Given this list of marker genes DNM1L, ATM, MAPT, COL13A1, CCDC141, HSD17B4, CLCN1, BBS10, SLC9A1, DNASE1L3, NDUFV2, CLN5, NAA20, GRIN1, ATP6V1A, FASTKD2, PHYH, GCK, CTSD, DLL1, ACBD5, OPA1, SLC16A2, TAT, GCH1, NDUFA4, HNRNPH2, SEMA6B, ATXN7, HEXB, NPC1, SLC2A3, MAP2K1, MT-TI, RORA, CLPB, MARS1, MLC1, ZBTB11, NDUFB10, USF3, TRIM8, CFAP418, YWHAG, ERCC6, KIF7, PDE6D, WARS2, YWHAE, SLC5A6, PEX11B, LIN28B, FGFR1, SLC1A3, ARL13B, ATP5F1E, CELF2, NPHP3, GABBR2, STN1, NR5A1, SLC6A19, LYRM7, PUM1, SMARCA2, MT-CYB, HTT, REPS1, GABRB3, BBS5, SLC44A1, CISD2, RARS1, SYNGAP1, PNP, TNFSF4, TERC (NCBI Gene Id 7012), SACS, TBC1D23, IQCB1, MKRN3, KARS1, CLCN4 (chloride voltage-gated channel 4), NPHP1, PDE2A, FZR1, HUWE1, PIGT, PAFAH1B1, POLG (DNA polymerase gamma, catalytic subunit), SMC1A, COQ2, CARS1, SLC30A9 (NCBI Gene Id 10463), IFNGR1, MEG3, COQ5, PGM3 (NCBI Gene Id 5238), BBS9, PDHX, GALT, TLR4, TSPOAP1, MT-ND4L, ADPRS, SUPT16H, CEP104, FGF14, FLRT3, PYCR2, MT-ND2, CAPN1, CHAMP1, AP3B2, NCF1, PIGQ, HK1, TUBB4A, TRIO, POLR3A, LMNB2, KCNJ11, CREBBP, SPRY4, ERAP1 (NCBI Gene Id 51752), FKBP6, IMPDH2, NONO, NANS, COA7, DCHS1, SORL1, ACOX1, ATN1, SDHA, EXOSC5, NDST1, AAAS, DDB2, RFXAP, ATP13A2 (ATPase cation transporting 13A2), SLC4A10, HERC1, STAT3 (NCBI Gene Id 6774), ALG11, RTEL1, PANK2, NPHP4, TXN2, HMGCL, MED13L, VPS37D, SOX10, ZNF592, UCHL1, SPTAN1, AHI1, SMAD4, MT-ND1, NECAP1, ETHE1, VPS13D, FGF12, NDUFAF2, NDUFAF3, CCDC88C, MPZ, DNAJC3, TOP3A, CEP164, HIVEP2, NRCAM, FRMD5, HCRT, ATXN1, TIA1, CPS1, SETD2, POLR3B, SLC13A5, DLK1, CAMTA1, DEGS1, NDUFA1, NHLRC1, HEPACAM, THG1L, FGF8, LGI3, MT-TW, NEMF, KLRC4, MAGEL2, RUBCN, RFT1, MAST1, ABCD1, EED, HNRNPH1, IL23R, NDUFAF6, PRPS1, EIF2S3, NEXMIF, LONP1, PDGFB, TMEM106B, EPRS1, SLC6A8, AMFR, NELFA, SLC5A7, GLB1, SLC13A3, MCOLN1, TCN2, NPC2, SPTBN1, SPTBN2, STAT4, PLA2G6, CYFIP2, MT-ND5, CPLANE1, MYCN, TANC2, GPRC5B, ATXN10, NADK2, ATP9A, AIFM1, PNPLA6, CTDP1, BMPR1B, HNRNPA1, MSH4 (mutS homolog 4), SMARCE1, VPS41, TPM3, NAXD, MTFMT (NCBI Gene Id 123263), MVK, ELOVL5, WDR81, VLDLR, MAG, PRKN, NUS1, DCC, PLEKHG4, BBS2, PI4KA, BRCA1, GPI, MTHFR, GRM1, HPDL, SLC22A5, TRNT1, SLC32A1, IQSEC1, SIK1, GCDH, NTN1, CLN6 (NCBI Gene Id 54982), MT-ATP6, SRPK3, UBTF, RUSC2, PACS2, NGLY1, GTPBP2 (NCBI Gene Id 54676), FBXL4, COQ8A, GTF2H5, CAMK2B, NSD2, VARS2, TBK1, NTRK2, SUFU, TRANK1, ADA2, NUP62, PLD3, WDPCP, NAA80, UBE3C, YME1L1, HTRA1, FRRS1L, NRAS, ZEB2, DNAJC5, IFT140, METTL27, GABRA1, SEMA3A, TPR, ATP5F1D, PIDD1, CSF1R, SLC18A2, HIBCH, CACNA2D1, DARS1, LRP4, TTC8, DNAJC19, CDC42BPB (NCBI Gene Id 9578), PEX7, SLC7A6OS, AP1S2, TBL2, SNAP25, NFIX, TMEM163, CLN8, MICOS13, LIG3, PPT1, PIBF1, MYO5A, GNAO1, ALDH18A1, CTNNA2, MECR (mitochondrial trans-2-enoyl-CoA reductase), TANGO2, ARL3, ERCC3, DPM1, TUBG1, NAGS, OCA2, NPAP1, LRP12, PEX1, B9D1, GABRA2, DAB1, SET, KLHL41, NEDD4L, DGUOK, TMEM63A, NDUFB3, SGPL1, APC2, SLC19A3, XRCC1, NDUFA6, PROK2, ENSG00000288330 (NCBI Gene Id 724066), NOP56, PDGFRB, HLA-DRB1, USH1G, SPTLC1, RFC2, PPP1R21, STXBP1, SLC38A3, PSMC3IP, TIMMDC1, KNSTRN, GRM7, ARCN1, SLC25A22, GPAA1, MORC2, BBS4, GABRG2, TREM2, BAZ1B, PPP2R1A, LMO1, PRKCG, SLC6A5, PEX10, UROC1, PDCD6IP, L1CAM, ABCA7, MRPL12, KLLN, PEX13, ATAD1, SETX, IRF2BPL, PWAR1, SLC12A3, MPDU1, KATNIP, MKKS, PCDH15, TDP2, MT-TQ, NAXE (NAD(P)HX epimerase), CLTC, PIGY, SNX14, VPS13C, POLR3K, DNMT1, EP300, ELOVL4, RTN2, SLC25A15, MTTP, CSTB, APC, UQCRQ, CLCNKB, SIGMAR1, ACTL6B, ATP7B, MAN2B1, PITRM1, LETM1, COG8 (component of oligomeric golgi complex 8), AARS2, AGTPBP1, PRODH, TECPR2, ARSG, NDNF, LMNB1, DARS2, NEUROD2, MT-CO2, PIGG, PSEN2, SYT14, UBAC2, SYNE1, GABRB2, MAPK8IP3, SNRPN, XPC, VPS51, FTL, TTBK2, AHDC1, PAX6, SLC19A2, MPV17, MAN1B1, DCX (doublecortin), GTF2E2, FMR1, GABRD, HLCS, LAMA1, SYT2, TDP1, WDR26, SCN1A, RAD50, PRRT2, CAPN3, HLA-DQA1, MYPN (myopalladin), POGZ (pogo transposable element derived with ZNF domain), SCLT1, BBS7, ZNF365, SPTB, AFF2, SIL1, MKS1, BTD, GMPPB, CEP41, TUBB2B, FTH1, AP2M1, CYP7B1, STX1A, PAK1, CEP78, ARX, CTSH, ANK1, L2HGDH, DCPS, VAMP1, PNKP, TBC1D2B, WASHC5, ZFHX3 (NCBI Gene Id 463), PMPCB, RAI1, PEX26, CTCF, NDUFS7, KIF5A, ACBD6, SPR, MBD5, PDYN, ARV1, ADGRG1, EXOSC9, MARS2, SNORD118, RPGRIP1L, CACNA2D2, DNM1, PRF1, FLVCR1, MT-TV, CC2D2A, CYP27A1 (cytochrome P450 family 27 subfamily A member 1), SMC5, CSNK2A1, AP4M1, WDR11, LMBRD1, SPART, TAF1, NEU1, GABRB1 (gamma-aminobutyric acid type A receptor subunit beta1), CAV3, NFASC (NCBI Gene Id 23114), NAA60, BEAN1, GOSR2, NTNG1, MT-TL1, NDUFB11, ABCC8, DPAGT1, NSD1, GPHN, IVD, LIMK1, NARS1, TMEM270 (NCBI Gene Id 135886), LAGE3, LRPPRC, WARS1, RFC1 (NCBI Gene Id 5981), PWRN1, NDUFA11, TTI1, VRK1, SEC23B, ACADS (acyl-CoA dehydrogenase short chain), FEZF1, GABRA5, TRAPPC11, SCO2, SCN2A, KCND3, OPHN1, ATP2B3, WWOX, PSEN1 (presenilin 1), BRAF, MECP2, AP5Z1, SFXN4, PSAP, RTN4IP1, MTR (5-methyltetrahydrofolate-homocysteine methyltransferase), SLC17A5, ADGRV1, SMPD1, WFS1, FAT2, SLC26A4, APTX, CHMP1A, MTRFR, NIPA1, SLC35A1, CNKSR2, PROKR2, SNORD115-1, USH2A, BRAT1, SAMD9L, ALS2, APOE, ACADM, POLR1C, ATPAF2, NEFL, BSCL2, CIITA, NF2, CMPK2, C19orf12, SBF2, SLC1A2, RNF113A, MT-RNR1, FGF13, SLC46A1, TMEM138, GAMT, COQ4, PIEZO2, ROGDI, PIGL, BCS1L, MT-TP, NR4A2, VPS13A (vacuolar protein sorting 13 homolog A), CDK19, SMARCB1, NF1 (neurofibromin 1), NDUFAF8, TMEM237, GRIK2, TUBB, PDP1, ADAR, PIK3CA (NCBI Gene Id 5290), PIGK, GFAP, SLC39A4 (solute carrier family 39 member 4), UBAP1, AMACR, CHD8, APOB, CLCNKA, HIC1, MOG, RIPK4, TMEM126B, PDHA1, CTC1, ABCB7, PIGA, FSHR, SLC52A2, LYST, MMADHC, TMEM216, IFT74, FA2H, CDH23, SDHB, TTN, POU3F4, PAK3, FKRP, PPP1R15B, TSHB, NUP54, PRDX3, ATXN3, SNF8, LITAF, TRPC3, MYD88, HARS1 (histidyl-tRNA synthetase 1), CACNA1G, SPAST, LZTFL1, B9D2, ITPR1, RTL1, MPLKIP, FAS, MT-ND3, EPM2A, NDUFS2, TSFM, HAX1, WDR73, ARMC9, CRAT, NDUFAF1, NDUFAF4, RFX5, OTC, RDH11, CNTNAP2, NDUFS1, MT-TH, MT-ATP8, TRAF7, PGAP3, PPP2R5D, HCN1, RNF170, SYNJ1, CTSF, SCN8A, SLC4A1, PRDM8, PGK1, CAPRIN1, MTPAP, RAB11B, CHD2, ATG5, ATP8A2, SLC35C1, ATP5MK, HMBS, SLC52A3, MME, MT-TN, SMO (smoothened, frizzled class receptor), TPK1 (NCBI Gene Id 27010), IRF4, PARS2, SLC9A6, ALDH5A1, NDUFAF5, GBA2, SCN1B, KCNC3, SLC25A1, MEFV, TBP, ELOVL1, CAV1, INS, TARDBP, GLRA1, DKC1, VPS4A, WHRN, TPP1, ERCC1, OTUD6B, TOPORS, NSUN2, AFG3L2, SPG7 (NCBI Gene Id 87549), ATP5F1A, GLS, ERBB3, SRPX2, GSN, FUS, TOMM40, DHX30, RNU12, CXCR4, NPTX1 (neuronal pentraxin 1), HLA-B, USH1C, HERC2, UBE3A, TWNK (NCBI Gene Id 60508), CHD7, FBXW7, TBCE, PEX6, NEB, BMP15, SRD5A3, NDUFS4, GTF2I, ESPN, ABHD12, STUB1, LINGO1, NALCN, HSD17B10, VWA3B, MT-ND4, EPB42, GJB1, PEX16, GNB5, ARID1B, ARL6, KDM4B, NIPA2, SPTA1 (spectrin alpha, erythrocytic 1), SARDH, SCN9A, KBTBD13, MCM3AP, FOXG1 (forkhead box G1), SDCCAG8 (NCBI Gene Id 10806), PIK3R5, STX1B, CHP1, ACOX2, GCLC, SOD1, MYORG, PDHB, TCF4, ALK, FERRY3, NKX6-2, TMEM107 (NCBI Gene Id 84314), SPG11, ALG13, SCN3A, ANO10, FOXRED1, DNAJC30, ELN, TMEM67, MLXIPL, AKT1, SDHAF1, POMT2, SZT2, SPG21, ALG6, CRELD1, RNASET2, DEAF1, IL17RD, PIGV, CHCHD10, TINF2, SCAPER, STARD7, GRIN2A, FOXP2, UFC1, KCNA1, KCNB1, RNF216, ATCAY, SNORD116-1, BCL11A, RNASEH1, PMM2, TRAPPC6B, GDAP1, CLCN2, PNPT1, PIGS (NCBI Gene Id 94005), BCKDHA, KIF1B, ALG8, AQP4, P2RY11, H4C5, BSND, PRX, CPLX1, SLC25A4, RNF125, BOLA3, GRIN2D, PURA, SQSTM1, TNPO2, EXOSC8, HACE1, CWF19L1, TTPA (NCBI Gene Id 7274), DMXL2, GDAP2, GJC2, RNU4-2, GALC, APP, TPM2, IL10, PLP1, SDHD (NCBI Gene Id 91899), SATB1, MAB21L1, ARSA, MSTO1, KCNC2, KCNJ16, KIAA0753, ITM2B, DNAJC6, NDUFS6, DALRD3, SLC6A1, KIF1A, SIM1, CEP120 (NCBI Gene Id 153241), PTPN22, MFSD8, IFT172, COX6B1, ATP6V0A1, PEX3, PHOX2B, TMEM70, MFN2, FRMD4A, ACD, HESX1, ANOS1, PEX2, PDX1, ATP1A3, CEP290, SH3TC2, PIGP, RPL10, ASL, PRICKLE1, PTEN, CLIP2, ASS1, MYO7A, DMPK, PIK3CD, MT-CO1, PIGO, MT-TS2, CEP19, GJA1, PCDH19, TUBA1A, CHAT, VCP, ACTA1, TUBB3, C4A, TGFB1, CLTRN, KIAA0586, PEX5, MT-CO3, TRIM32, PEX12, NUP214, DUSP6, KDM5B, ATXN8OS, SHMT2, ALMS1, PGM2L1, PEX14, MICU1, SUMF1, TARS1, BAP1, CBY1, CTBP1, TMEM218, RIMS2, MT-TK, JAM2, GTF2IRD2, POLR1A, DHFR, PIGW, TH, ATP6V0A2, ATAD3A, COG5, COG4, ERCC8, XRCC4, NDUFS8, ZNF142, SLC25A46, AASS, SURF1, GTF2IRD1, FAM149B1, HLA-DQB1, GLRX5, OGDH (oxoglutarate dehydrogenase), TTC19, RPIA, ERCC4, CP, COA8, PEX19, TGM6, SPEN, RFXANK, PPP3CA, DOCK3, CDKL5, KDM5A, TTR, NOTCH2NLC, ZFYVE26, PRNP, DNAL4, ATG7, MYT1L, KCNC1, CLRN1, ABHD5, AARS1, ZSWIM7, TBCD, CUX1, CCR1, ABCA2, MYO9A, SCYL1, COX10, NUBPL (NCBI Gene Id 80224), NUP107, MT-TF, MRE11, ABHD16A, KIF1C, EEF2, PRDM13, MFSD2A, EIF4H, TMEM231, SLC39A14, RAD51, SIN3A, COL18A1, DPYSL5 (NCBI Gene Id 56896), DHX9, PPP2R2B, CACNA1A (NCBI Gene Id 773), TBC1D24, GEMIN5, SLC2A1, AUH, RRM2B, EXOSC3, RNF168, TMEM240, ATP10A, ERCC5, GNE, DKK1, IL12A, DHDDS, LNPK, OXR1 (oxidation resistance 1), TCF20, MT-TE, DOHH, BNC1, KCNJ10, TERT, ZNF423, SLC18A3, IFRD1 (NCBI Gene Id 95049), FRMPD4, EZH2, CUL4B, SNAP29, CASK (NCBI Gene Id 8573), GMPPA, TCTN2, NFU1, PGAP2, GGT1, SUOX, CERS1, SDHC, SYT1, PNPLA8, ATP6AP2, POMT1, ASAH1 (N-acylsphingosine amidohydrolase 1), WDR19, ZBTB20, GRN, CBS, POLG2, POLR3H, B4GALNT1, ATP1A2, GBE1, GBA1, BBS1, MRPS22, GLRB, SLC25A42, KIT, ERMARD, SLC30A10, BCKDK, GRID2, CACNA1B, XPA, FGF17 (NCBI Gene Id 8822), CACNB4, TRAF3IP1, COX20, EIF2AK2, SARS1, BBIP1, HIKESHI, GRIA2, BBS12, ELP1, INPP5E, IL12A-AS1, PDE8B, FXN, LARS2, NDUFA13, FBXO28, CDC42, LARGE1, NDUFV1, ZSWIM6, TCTN3, TCTN1, TK2, RNF220, MT-ND6, KCNA2, TOGARAM1, NDUFB9, NAT8L, PMP22, HS6ST1, DLD, PMPCA, NUTM2B-AS1, CCDC28B, UBA5, CA8, PARN, NMNAT1, NDUFS3, NOL3, FOXI1, KCNQ2, TEFM, P4HA2, EEF1A2, TPRKB, TOE1, NKX2-1, DPP9, MMACHC, ERCC2, PCNA, OFD1, DLAT, ATXN2, PODXL, GSS, FOCAD, TRAK1, PTRH2, CSPP1, HYLS1, CIB2, KCNN2, EDNRB, SPIDR, PTS, INVS, SCARB2, SLC20A2, REEP2, AGRN, KCNMA1, ACAT1, SUCLA2, OPA3 (NCBI Gene Id 8186), FAT4, DYRK1A, ADSL, TELO2, ACO2, SNAI2, KCTD7, POU4F1, FDXR, PDZD7, ABCA5, TACR3, EBF3, IFT27, RYR1, BUD23, here is a description of the gene set: species: Homo sapiens Abnormality of coordination Human Gene Set: HP_ABNORMALITY_OF_COORDINATION